The following is a description of a gene set: Human Gene Set: REACTOME_MHC_CLASS_II_ANTIGEN_PRESENTATION species: Homo sapiens MHC class II antigen presentation, and this is the list of marker genes: TUBB2B, AP2S1, AP1S2, TUBB6 (tubulin beta 6 class V), KIF26A, RACGAP1, KIF3B, AP1G1, TUBB3, TUBA3D, CTSL, CANX, ACTR10, SEC31A, ACTR1B, KLC4, DCTN6, DCTN2, AP1S1, RAB7A, DCTN4, TUBB2A, HLA-DPA1, SEC24C, DCTN3, HLA-DRA, HLA-DRB3, KIF3C, HLA-DQB2, TUBB4A, KIF2B, HLA-DQA2, SEC13, HLA-DQA1, DYNC1LI1, CTSV, KIF5B, SPTBN2, CLTC, AP1B1, KIF20A, IFI30, CTSE, CTSC, CTSD, HLA-DRB4, DCTN1, ARF1, AP2M1, DYNC1LI2, CD74, KIF11, TUBA1C, CAPZA2, TUBA4A, TUBB8, ACTR1A (actin related protein 1A), CTSS, DYNC1I1, CTSF, CTSH, SAR1B, KLC3, KIF23 (kinesin family member 23), DNM3, HLA-DPB1, TUBA3C, KIF4A (kinesin family member 4A), TUBA4B, HLA-DOB, DNM2, DYNLL2, RILP, DCTN5, CAPZA3 (capping actin protein of muscle Z-line subunit alpha 3), TUBA3E (NCBI Gene Id 150521), KLC2, DYNC1H1, CAPZA1, CTSK, OSBPL1A, SEC24A, AP2B1, SEC24D, HLA-DRB1, TUBB1, KIF2A, SEC24B, TUBB8B, KIF5A, HLA-DRB5, CTSB, CLTA, AP1S3, HLA-DMA, KIF15, KIFAP3, KIF4B, KIF18A, DNM1, CENPE, AP1M1, KLC1, KIF2C, LGMN, SH3GL2, CTSO, SEC23A, CAPZB (capping actin protein of muscle Z-line subunit beta), AP2A2, TUBA8, TUBAL3, AP2A1, TUBA1A, LAG3, HLA-DQB1, TUBB4B, KIF22, AP1M2, CTSA, DYNLL1, HLA-DMB, DYNC1I2, KIF3A, TUBA1B, HLA-DOA